Given this list of marker genes Tmem102, Ccl19-ps5, Ptk2b, Ccl26, Vegfa, Ripor2, Fpr-rs3, Ccl2, Calr, Pdgfd, Tgfb1, S1pr1, Adam17, Camk1d, Lpar1, Adam10, Hmgb1, Ccr1, Dapk2, Spi1 (Spi-1 proto-oncogene), Perp, Ccl1, Wnt5a, Cxcl17, Ptn, Swap70, Pgf, Ccl7, Ccl21b, Wasl, Sema5a, Scg2 (secretogranin II), Megf8, Fpr-rs7, Ccl21f, Dnm1l, F7, Nrp1, Serpine1, F2rl1, Hspb1, Smad3, Stx4a, Pdgfb, Rac2, Mapk3, Cmklr1, Ppm1f, Fgfr1, Sell, Fgf18, Mospd2, C1qbp, Defb25, Edn2, Zfp580, Sucnr1, Ccr2, Ccr1l1 (NCBI Gene Id 12770), C5ar1, Trem2 (NCBI Gene Id 83433), Mapk1, Cxcr2, Tmsb4x, Csf1r, Ccl5 (C-C motif chemokine ligand 5), Fpr-rs6, Ppbp, Ednra, Mdk, Fpr2, Thbs1, Mcu, Tirap, Itga2, Cxcr4, Rac1, App, Ccr6, P2ry12, Fgf10 (fibroblast growth factor 10), Thbs4, Ccl19, Cxcl13, Il12a, Cxcr3, Il23a, Csf1, Cx3cl1, Shh, Ccl21a, Pdgfrb, Nedd9, Smoc2, Fgf2, Aif1, Ntrk3, Cxcl14, Creb3, Ntf3, Cxcl12, Xcl1, Ccr7, Stk39, Ccl3, Cx3cr1, Artn, Oxsr1, Ccl19-ps4, Ccl21e, Fn1, Trem1, Dysf, Ccl21d, Ccr4 (NCBI Gene Id 12773), Wnk1, Rarres2, Gas6, Tnfsf14, Il34, Cttn, Ptk2, Edn1, Akirin1, Prkca, Vegfd, Cxcl10, C3ar1, Vegfc, Kdr, Pdgfra, Bmpr2, Il4, Ano6, Dscam, Ptprj, Il16, Tiam1, Snai2, Casr, Trpv4, Cdh13, P2rx4 (NCBI Gene Id 52272), Akt2, Nckap1l, Slamf1, S100a14, Slit2, Prkd1, Il1b, Lgmn, Tpbg, Prkd2, Stx3, Gpsm3, Ccl19-ps3, Fpr-rs4, Fgf16, Edn3, BC037156 (cDNA sequence BC037156), Ager, Met, Lbp, Ccl19-ps1, Cd74, Tnfsf18, Mstn, Pla2g7, Ccl19-ps6, Vegfb, here is a description of the gene set: studied in species Mus musculus Mouse Gene Set: GOBP_POSITIVE_REGULATION_OF_CHEMOTAXIS Any process that activates or increases the frequency, rate or extent of the directed movement of a motile cell or organism in response to a specific chemical concentration gradient.